The following is a description of a gene set: The chemical reactions and pathways involving ketone body. species: Mus musculus Mouse Gene Set: GOBP_KETONE_BODY_METABOLIC_PROCESS, and this is the list of marker genes: Hmgcll1, Oxct2a, Oxct2b, Dgat1, Oxct1, Hmgcs2, Tyrp1, Slc27a5, Acat1, Hmgcl